Given this list of marker genes Fbn2, Cer1, Nbl1, Fbn1, Nrros, Ltbp1, Dand5, here is a description of the gene set: Any process in which a protein is maintained in a specific location within the extracellular region and is prevented from moving elsewhere. Mouse Gene Set: GOBP_MAINTENANCE_OF_PROTEIN_LOCATION_IN_EXTRACELLULAR_REGION studied in species Mus musculus